Given this list of marker genes Frs2, Fgf1, Fgf5, Mapk3, Rps27a, Hras, Flrt2, Fgfrl1, Fgf6, Spry2, Kl, Fgf4, Gipc1, Fgf10, Fgfr1, Fgf22, Fgf17, Fgf8, Fgf23, Shc1, Flrt1, Ubb, Fgf2, Grb2, Gab1, Fgf20, Cbl, here is a description of the gene set: part of: Signaling by FGFR Reactome Pathway: Signaling by FGFR1 species: Mus musculus electronically inferred by orthology from the curated human pathway This event has been computationally inferred from an event that has been demonstrated in another species.<p>The inference is based on the homology mapping from PANTHER. Briefly, reactions for which all involved PhysicalEntities (in input, output and catalyst) have a mapped orthologue/paralogue (for complexes at least 75% of components must have a mapping) are inferred to the other species.